Given this list of marker genes CTNNB1, PTPN22, PRTN3, CTLA4, HLA-DPA1, HLA-DPB1, here is a description of the gene set: Anti-myeloperoxidase antibody positivity The presence of autoantibodies in the blood circulation that react against myeloperoxidase. Human Gene Set: HP_ANTI_MYELOPEROXIDASE_ANTIBODY_POSITIVITY studied in species Homo sapiens